The following is a description of a gene set: studied in species Homo sapiens Lipoprotein lipase (LPL) and hepatic triacylglycerol lipase (LIPC) enzymes on the lumenal surfaces of capillary endothelia mediate the hydrolysis of triglyceride molecules in circulating lipoprotein particles.<br>LPL is widely expressed in the body and is especially abundant in adipocytes and skeletal and cardiac myocytes. Activation of the protein requires glycosylation, dimerization, and glycosylphosphatidylinositol-anchored high density lipoprotein-binding protein 1 (GPIHBP1), which delivers it to heparan sulfate proteoglycan (HSPG) associated with the plasma membrane. It is inactivated by proteolytic cleavage (Berryman & Bensadoun 1995; Sukonina et al. 2006; Young et al. 2011).<br>Expression of the LPL gene is transcriptionally regulated by Cyclic AMP-responsive element-binding protein 3-like protein 3 (CREB3L3), which also regulates the expression of APOA4, APOA5, APOC2, CIDEC and FGF21.<br>Maturation of LIPC enzyme requires association with LMF1 protein (or possibly, inferred from sequence similarity, LMF2). Heparin binding stabilizes LIPC in its active dimeric form (Babilonia-Rosa & Neher 2014). part of: Plasma lipoprotein remodeling Reactome Pathway: Assembly of active LPL and LIPC lipase complexes, and this is the list of marker genes: PCSK6, CIDEC, LIPC, MBTPS2, ANGPTL8, FURIN, APOC2, LMF1, PCSK5, LPL, CREB3L3, APOA5, LMF2, GPIHBP1 (glycosylphosphatidylinositol anchored high density lipoprotein binding protein 1), MBTPS1, ANGPTL4, FGF21, ANGPTL3, APOA4